The following is a description of a gene set: Ubiquitination, the modification of proteins by the covalent attachment of ubiquitin (Ub), is a key regulatory mechanism for many many cellular processes, including protein degradation by the 26S proteasome. Ub conjugates linked via lysine 48 (K48) target substrates to the proteasome, whereas those linked via any of the six other Ub lysines can alter the function of the modified protein without leading to degradation. Deubiquitination, the reversal of this modification, regulates the function of ubiquitin-conjugated proteins. Deubiquitinating enzymes (DUBs) catalyze the removal of Ub and regulate Ub-mediated pathways.<br><br>Given that Ub is covalently-linked to proteins destined to be degraded, it is a surprisingly long-lived protein in vivo (Haas & Bright 1987). This is due to the removal of Ub from its conjugates by DUBs prior to proteolysis. This may represent a quality control mechanism that prevents the degradation of proteins that were inappropriately tagged for degradation. DUBs are responsible for processing inactive Ub precursors and for keeping the 26S proteasome free of unanchored Ub chains that compete for Ub-binding sites. <br><br>DUBs can be grouped into five families based on their conserved catalytic domains (Amerik & Hochstrasser 2004). Four of these families are thiol proteases and comprise the bulk of DUBs, while the fifth family is a small group of Ub specific metalloproteases. <br><br>Thiol protease DUBs contain a Cys-His-Asp/Asn catalytic triad in which the Asp/Asn functions to polarize and orient the His, while the His serves as a general acid/base by both priming the catalytic Cys for nucleophilic attack on the (iso)peptide carbonyl carbon and by donating a proton to the lysine epsilon-amino leaving group. The nucleophilic attack of the catalytic Cys on the carbonyl carbon produces a negatively charged transition state that is stabilized by an oxyanion hole composed of hydrogen bond donors. A Cys-carbonyl acyl intermediate ensues and is then hydrolyzed by nucleophilic attack of a water molecule to liberate a protein C-terminal carboxylate and regenerate the enzyme. Ub binding often causes structural rearrangements necessary for catalysis. Many DUBs are inactivated by oxidation of the catalytic cysteine to sulphenic acid (single bond SOH). This can be reversed by reduction with DTT or glutathione. The sulphenic acid can be irreversibly oxidized to sulphinic acid (single bond SO2H) or sulphonic acid (single bond SO3H). <br> <br>Thiol proteases are reversibly inhibited by Ub C-terminal aldehyde, forming a thio-hemiacetal between the aldehyde group and the active site thiol. species: Homo sapiens part of: Post-translational protein modification Reactome Pathway: Deubiquitination, and this is the list of marker genes: PSMB4, UBB, VDAC1, BAP1, H2BC4, ARRB1, UFD1, EP300, ATXN3, ACTR8, USP16, MYSM1, ACTR5, TAB1, CDC20, RHOA, FOXK2, USP26, ESR1, OTUD7A, PSMA7, SMURF2, RCE1, USP8, PSMD1, YY1, UBA52, H2BC17, VDAC2, PSMA3, USP11, H2AC14, OTUD3 (OTU deubiquitinase 3), INO80D, GATA3, UCHL1, TGFBR2, UBE2D1, CCNA2, H2BC21, STAMBPL1, USP17L12, CLSPN, H2AC12, ABRAXAS1, RHOT1 (NCBI Gene Id 55288), SNX3, USP17L1, TNKS2 (NCBI Gene Id 94771), BABAM1, DDB2, USP17L2, USP17L5, IDE, PSMD11 (proteasome 26S subunit, non-ATPase 11), USP17L3, USP7, H2BC13, INO80E, SKP2, USP17L24, NEDD8, INO80B, USP17L11, TRRAP, USP49, USP20 (NCBI Gene Id 10868), USP12, APC, USP17L4, USP17L17, TOMM20, SEM1, OTUB1, STAMBP, TADA2B, WDR48, OTUB2, PSMC6, SMAD7 (NCBI Gene Id 4092), ASXL1, YOD1, PSMC5, USP24, USP9X, ADRM1, PSMD6, PSMC3, USP34, CDC25A, PSMB2, SIAH2, USP17L20, PSMB5, USP22, USP15, H2BC26, CYLD, FOXK1, USP5, PSMA2, RAD23A, PSMA4, PSMB1, PSMD8, TRIM25, PSMD2, H2AC20, FKBP8, PSMD13, H2AC25, KEAP1, RAD23B, TP53, ABRAXAS2, RIPK2, PSMC4, H2AC18 (NCBI Gene Id 8337), H2AC4, PSMD12, PSMB7, USP3, BIRC2, TADA3 (transcriptional adaptor 3), VCPIP1, TNKS, ACTL6A, TRAF6, USP19, USP17L8, H2BC18, TAF9B (NCBI Gene Id 51616), RNF128, BECN1, IKBKG, ZRANB1, USP33 (NCBI Gene Id 23032), NLRP3, VCP, MYC, ATXN7, INO80C, USP4, TGFBR1, SUDS3, TNIP1 (TNFAIP3 interacting protein 1), MDM2, USP18 (NCBI Gene Id 11274), USP13, ASXL2, BRCC3, H2AC6, IFIH1, TNIP3, TRIM4, KDM1B (NCBI Gene Id 254751), RNF135, PSMC1, H2BC3, USP17L19, PRKN, NFRKB, USP17L15, SMAD3, RNF146, BIRC3, H2BC12, INO80, CFTR, STAM, PSMD7, TRAF2, USP28, USP17L22, USP14, RIGI, RNF123, CCP110, USP30, PSMA6, KAT2A, HGS, H2AC7, ACTB, IL33, H2BC14, ATXN3L, MUL1, MBD5, PSMB6, H2BC15, TNFAIP3, MBD6, JOSD1, HCFC1 (NCBI Gene Id 8267), STAM2, PTEN, PSMD3, AR, H2BC11, TGFB1, SENP8, USP44, TOMM70, RPS27A, VDAC3, PSMD14, SMAD1, NOD2, OGT, PSMA5, USP10, MAT2B, SMAD4, KAT2B, USP17L13, AXIN1, PTRH2, H2BC5, USP21, UBC, BABAM2, UCHL3, MAP3K7, BRCA1, PSMC2 (proteasome 26S subunit, ATPase 2), CCNA1, PSMB3 (NCBI Gene Id 5691), MDM4, MCRS1, H2AC1, WDR20, H2AC21, USP17L18, MAVS, RIPK1, AXIN2, ARRB2, USP2, FOXO4, TNIP2, OTUD7B, POLB, USP17L21, USP48, USP47, SMAD2, USP37, H2BC9, UIMC1, RUVBL1, USP42 (NCBI Gene Id 84132), CDK1, H2BC1 (H2B clustered histone 1), TAF10, JOSD2, OTUD5, NFKBIA, H2AC11, TFPT, USP25, BARD1, ADRB2, UCHL5, NOD1, USP17L10, HIF1A, PSMA1, TRAF3